Given this list of marker genes MACROH2A1, SLC25A39, BLM (BLM RecQ like helicase), ITGAX, PDE3B (phosphodiesterase 3B), GALNS, BEND4, EOMES, TMEM69, SLCO3A1, PNKP, TSPAN4, NUP210, DALRD3, GEM, MFSD10, MAPRE1, NAGA, HMGA1, IFT27, ARPC2, MAP7D1, ACACA, RRBP1, MRPL23, CDT1, FKBPL, MCM3, GRWD1, DDOST, PIGA, NUP205, SYT4, CCDC91, TNS4, USP47, RAD51AP1, PTPN6, PABPC1, OSBPL3, POLR1B, SAMD10, SLC35C1, SMPD5, OXGR1, NUP93, PDLIM5, RPTOR, FSTL1, DNAJC3, SRPX2, CNTNAP4, PLCH2, KLHL4, GALK1, CCHCR1, ARMC7, INSRR, SCO1, NARS2, NBEAL2, SRSF12, ACOXL, UNC93B1, PSME3, WAS, RNASEH2C, DNAJA2, PGLYRP1, RAN, ZNF507, FAM204A, TIRAP, ARAP2, RHAG, ASH2L, ATXN7L3B, GAB3, AOAH, ZP3, VAT1, ARL4D, WWP1, SLC45A3, RIOK1, RFX7, GID4, PNPLA2, UBE2M, CD226, DCAF7, YEATS2, FHL5, ACVR1, AKT1S1, HSD17B12, CUL9, OLFM1, BAIAP3, ODAD4, RABEPK, COIL, ARHGEF38, S100A1, GTDC1, CENPV, LRRC14, POU2AF2, NCDN, PPM1G, SAMM50, ZDHHC6, DCN, MIDEAS, SPRY2, PRMT5, CLEC14A, EXOC4, THUMPD1 (THUMP domain containing 1), CENPJ, SCAP, EYA3, SMOC2, POU3F2, EFR3A, IFT172, CD72, PLEKHA5, HGF, GNAS (NCBI Gene Id 82944), UBA1, TCIM, CALHM6, OR51E1, TGM2, SMAD3, VIPAS39, TPSG1, PDE7A, CARM1, ARHGAP30, SLC25A36, EDEM3, CCL22, SIPA1 (NCBI Gene Id 6494), PCYOX1L, MTG1, ADGRF5, MAVS, ST3GAL6, ZWILCH, MYPOP, RNPEPL1, CCR5, HOXD9, MZB1, IL17A, KIF2A, EVI2B, TENT5A (NCBI Gene Id 55603), C17orf100, ALDH18A1, GRM5, COX8A, LAP3, SH2D6, EI24, NDNF, YPEL1, G3BP1, EXOC6, ARAP3, LRRK1, ACD, SECISBP2, METTL5, GNMT, TRIM13, PPP3R1, VPS50, NOP2, PDE12, OSTF1, TM6SF1, ENTPD7, C1orf21, PKP4, ZNF606, ANAPC5, KRT28, THTPA, HSD17B14, TTC29, PTPN12, ZNF619, LGALS9B, TRAPPC8, RGR, IST1, MEF2A, here is a description of the gene set: Each fraction of mouse hematopoietic cells was purified by cell sorting from bone marrow of 8-week-old C57BL/6 mice, and its gene expression was analyzed. Genes down-regulated in comparison of CD4 T cells versus NKT cells. species: Homo sapiens from publication Konuma T, Nakamura S, Miyagi S, Negishi M, Chiba T, Oguro H, Yuan J, Mochizuki-Kashio M, Ichikawa H, Miyoshi H, Vidal M, Iwama A (PMID 21540074) Human Gene Set: GSE27786_CD4_TCELL_VS_NKTCELL_DN